Given this list of marker genes Psmb6 (proteasome (prosome, macropain) subunit, beta type 6), Psmc4, Ptk6, Ccne2, Psmc1, Psmb2, Psma6, Skp2, Ccnd1, Cks1b, Psmd2, Psma7, Psmc6, Psma5, Psmb3, Ccne1, Psmd3, Cul1, Psmd1, Psmd8, Psma2, Cdk2, Ccna2, Cdkn1a, Cdk4, Psmb4, Psmb5, Psmd13, Psmb1, Uba52rt, Skp1, Psmd6, Psmd14, Psmd12, Ubc, Psmc5, Cdkn1c, Psma3, Psmd11, Cdkn1b, Uba52, Ccna1, Adrm1, Psmb7, Psmc2, Psma1 (NCBI Gene Id 26440), Psmc3, Psma4, Rps27a, Psmd7, Ubb (ubiquitin B), here is a description of the gene set: species: Mus musculus SCF(Skp2)-mediated degradation of p27/p21 Mouse Gene Set: REACTOME_SCF_SKP2_MEDIATED_DEGRADATION_OF_P27_P21